Given this list of marker genes Lmo3, Akap13, Ntrk2, Crebrf, Cry2, Per1, Ppp5c, Cry1, Nr3c1, Clock, Ncoa2, Bmal1, Bdnf, Phb1, here is a description of the gene set: Any process that modulates the frequency, rate or extent of nuclear receptor-mediated glucocorticoid signaling pathway. Mouse Gene Set: GOBP_REGULATION_OF_NUCLEAR_RECEPTOR_MEDIATED_GLUCOCORTICOID_SIGNALING_PATHWAY studied in species Mus musculus